Given this list of marker genes AMPD2, B4GALNT1, TWNK, ABCD1, GBA2, KCND3, CPT1C, MTRFR, LRSAM1, ATP1A1, CADM3, KIF5A, MAG, XK, UCHL1 (NCBI Gene Id 7345), RNF170, PMP22, KCNC3, SETX, PDYN, GCH1, CHCHD10, POLG, XRCC1, PDXK, JAG1, KIF1A, PEX10, EGR2, SPG11, MPZ, PRX, DHH, REEP2, NDRG1, FMR1, GDAP1, PMP2, CACNA1G, MORC2, LMNB1, POLR3B, DHTKD1, SH3TC2, PDK3, SPART, CHP1, SPAST, DCAF8, APTX, ALDH18A1, PRKCG, NEFL, VCP, here is a description of the gene set: Impaired distal vibration sensation species: Homo sapiens Human Gene Set: HP_IMPAIRED_DISTAL_VIBRATION_SENSATION A decrease in the ability to perceive vibration in the distal portions of the limbs.